Given this list of marker genes EPC2, LMCD1, CDC42EP3, LINC01597, RAP2B, ANKRD23, PIK3R3, RASGRF1, XIRP1, STBD1, TMEM255A, ART5, USP2, SLC12A5, NEIL3, LINC00670, NEXN-AS1, SMPX, TLCD5, STAC, MYOZ2, ASB16, RASGRP3, METTL8, SUPT4H1, ADCYAP1, DRD3, AOC2, DMD, WT1-AS, TSC22D1, SPIB, RARA, HAPLN1, ARR3, AQP1, COL8A1, RASGRP2, FGF12, SLC44A1, SDHC, NR2F1 (nuclear receptor subfamily 2 group F member 1, NCBI Gene Id 7025), PRRX1, LIX1, HDAC7, TRMT10A, H3C1, AKAP1, SLC2A4, SGCD, AMD1, MCU, ESAM, MOSMO, BZW2, ARHGEF15 (Rho guanine nucleotide exchange factor 15), PPP1R3A, TRIM8, MYH3, H1-1, LRRC20, PURA, RNF207, NFAT5, RASGEF1B, MYOM2, DYRK2, CSRP3, PTCH1, CELF4, CASQ2, TIMP2, MYBPC2, ELAVL4, NFATC1, EFHD1, SCN4B, SOX5, TTYH2, ITGA7, TLK2, RHOBTB1, DBNDD2 (dysbindin domain containing 2), ADGRD1, CPT1B, PTPRO, MYOZ1, HOXB7, DLG2, LIF, RETREG1, HSPB3, H4C1, ASB4, CASZ1, SCML1, GCG, MYH4, GRIN2B, IGF1, PTCHD4, CKM, PHOSPHO1, EYA1, HES1, NAT8L (N-acetyltransferase 8 like), ENO3, PPARGC1A, AMPD1, TRPM4, LOXL4, BCL9L, TNNI3K (NCBI Gene Id 51086), NR0B2, MEOX2, SLC30A1, MIA2, SNCAIP, LPAR4, TNNI1, REEP1, CSDE1, RALY, DIRAS1, MRPS23, THBS2, SMYD1, PVALB, ALPK2, SLC12A8, ZBTB18, AHNAK, DKK4, PALLD, EMB, NFIL3, FOXP1, PMEPA1, COL10A1, TNNC2, CLCN1, PRX, PLAGL2, FGF6, TRHR, RCOR1, CDC42EP2, ADAMTSL1, S100A4, ITGB3BP, CORO6 (coronin 6), IRS1, NOG, CTNND2 (NCBI Gene Id 1501), ZIC4, KCNN1, TOB2, SMARCA2, MYF6, POU3F4, PLSCR4, EGR2, SMAD3, FBXW11, DES, TWIST1, TYRO3, LZTS2, DMP1, SLC8A3, PCDHB1, HAO1, PCDH11Y (protocadherin 11 Y-linked), TUBA4B (NCBI Gene Id 80086), ATF3, NDRG2, TRDN, OPN3, ATL2, TSC1, H2AC1, SOX9, MAT2A, DNAJA4, NTS, LRRTM1, MYH2, TUBA4A (NCBI Gene Id 93373), SV2A, SPTB, NEK2, SYNPO2L, USP47, CCDC91, JUN, CHN2, BAMBI, CBLN4, GABRB2, TRIM63 (tripartite motif containing 63), H2BC1, ARHGEF38, YJEFN3, ITGA10, TRIB2, PPP1R3D, CD24, IL4, CNTN1, RIMS2, MACO1, GRIN2D, PANK1, NPTXR, WIPI1, SLC25A4, ATP2A3, KRT222, HOXD4, IKZF2, EIF5A, FGF4, LRRTM4, SIPA1L1, PDZRN4, EEF1A2, ADAM11, KLHDC8B (kelch domain containing 8B), TSPAN13, PLEKHA6, H1-2, DPYSL3 (dihydropyrimidinase like 3), ESR1, TEF, UBE2E4P, GIT1, RRAD, LYPD1, NCAN, CYP2E1, SH3GLB2, PITX2, PPP2R2A, POU4F1, LSMEM2, IFNB1, MID1IP1, MGAT3, FAP, XK, TMEM117, HSPB1, TPM3, CPNE7, CYP26B1, MAP2K5, CAPN3, RHOBTB3, STC1, PRKAG1, ACTN3, CACNB1, STAU1, GPC4, FAM117A, SIK3, BNC2, COL13A1, ELMO2, HRC, KLHL40, SLC32A1, MUSK, FBXO40, CD36, SLC9A5, NR4A1, ATP2B4, KCNQ5, MBOAT2, PHKA2, GPR153, NME5, ASPH, STAG2, NNT, ALDOA, OTUD7B, HBEGF, RAB2A, SLC7A1, MGST3, KTN1, MYH8, CKB, GPR157, GYG1, ABLIM1, KCNJ2, HOXC4, LGALSL, MYL1, S1PR1, SYTL2, RPA3 (replication protein A3), GPCPD1, CPEB4, SIX3, DCAF17, PATE1, PRMT3 (protein arginine methyltransferase 3, NCBI Gene Id 10196), KLHL41, TPM2, CACNA2D3, SLITRK4, ARHGAP36, PDE6D, GPBP1L1, GPRASP3, RHOQ, WFDC1, ZDHHC24, TTC17, GSC, LINC00303, ITSN1, SLC26A6 (NCBI Gene Id 65010), EPHX4, ANKMY2, NDP, PATZ1, PCDH11X, DST, TCEA3, FITM1, RAP2C, HOXB4, KRT77, ARMCX6, ZC3H10, IGSF21, PAK6, GPM6B (glycoprotein M6B), FGB, ACTA1, MB, DGKI, NCOR1, TNFRSF17, CFL2, EPHA7 (EPH receptor A7), MAB21L2, CA7, TNNI3, POFUT1, ANGPT4, KY, TSPAN14, ART3, CASQ1, INPPL1, PER1, HDAC9, CRTAP, C10orf71, CUL3, RGS9BP, here is a description of the gene set: Comprehensive identification of all functional elements encoded in the human genome is a fundamental need in biomedical research. Here, we present a comparative analysis of the human, mouse, rat and dog genomes to create a systematic catalogue of common regulatory motifs in promoters and 3' untranslated regions (3' UTRs). The promoter analysis yields 174 candidate motifs, including most previously known transcription-factor binding sites and 105 new motifs. The 3'-UTR analysis yields 106 motifs likely to be involved in post-transcriptional regulation. Nearly one-half are associated with microRNAs (miRNAs), leading to the discovery of many new miRNA genes and their likely target genes. Our results suggest that previous estimates of the number of human miRNA genes were low, and that miRNAs regulate at least 20% of human genes. The overall results provide a systematic view of gene regulation in the human, which will be refined as additional mammalian genomes become available. Genes having at least one occurrence of the highly conserved motif M28 CTAWWWATA in the regions spanning 4 kb centered on their transcription starting sites. This matches the MEF2A transcription factor binding site V$RSRFC4_Q2 (v7.4 TRANSFAC). Human Gene Set: CTAWWWATA_RSRFC4_Q2 species: Homo sapiens from publication Xie X, Lu J, Kulbokas EJ, Golub TR, Mootha V, Lindblad-Toh K, Lander ES, Kellis M (PMID 15735639)